The following is a description of a gene set: Abnormal increase or decrease of absolute number of granulocytes in the blood, per microliter, compared to a reference range for a given sex and age-group. Abnormal granulocyte count Human Gene Set: HP_ABNORMAL_GRANULOCYTE_COUNT studied in species Homo sapiens, and this is the list of marker genes: UNC93B1, TONSL, MTR, NLRP1, STXBP2, SPI1, CASP10, FANCE, RPS28, IL6ST, CXCR2, RNF113A, AP3B1, FAS, LAMTOR2, CDC40 (cell division cycle 40), MDM4, CSF3R, TSR2, DNAJC21, RPL35, STK4, ICOS, CD40, TLR8, PRF1, G6PC3, RPS26, SRP19, MECOM, PCCB, FIBP, CARD10, SLC35A1, PRKAR1A, STAT1, MMAB, PSMB10, ZBTB16, IFNG, JAGN1, ATRX, NABP1 (NCBI Gene Id 64859), GFI1, RPS24, TCIRG1, WAS (NCBI Gene Id 7454), TERT, TBX21, UBE2A, FCGR3B, KIT, TBL1XR1, RECQL4, RPL35A, AP3D1, RPS20, CARS1, CXCR4, PCCA, TINF2, ITCH, ETV6, ABCD4, DIAPH1, VPS33A, VPS45, MVK, MPLKIP, AK2, CD3D, IGLL1, MMACHC, RAC2, TLR3, LRRC8A, UNC13D, PACS2, NR3C1, TICAM1 (NCBI Gene Id 148022), RPL18, SMARCAL1, ZAP70, XIAP, FASLG, RBM8A, CARD9, JAK1, PIK3CG, FBXL4, CHD7, FDX2, NDUFA6, TRAC, FANCI, EPG5, MEFV, MTRR, GTF2E2, GTF2H5, BCL11B, RPL31, BCOR, TFR2, CDH23, USP8, PPIL1, EIF2AK3, STAT6, COG4, PRDX1, WIPF1, DOCK11, RAG1, SAMD9L, FBXW7, GINS1, BTK, TRAF3, TPP2, CRELD1 (cysteine rich with EGF like domains 1), ANAPC1, EFL1, LIG4, TAFAZZIN, BACH2, RPS7, RFX5, ARPC5 (NCBI Gene Id 10092), SRSF2, RPS29, FNIP1, BLNK, FIP1L1, PGM3, OTULIN, CEBPE, SRP54, PIK3CD, NLRP3, GATA2, RPL15, HLA-DRB1, TP53, RPS27, ICOSLG, STAT3, CBL, RPS17, FMO3, ERCC2, IL36RN, NUMA1, HEATR3, ASXL1, RAB27A, MAD2L2, IRF8, CDSN, EXTL3, RPL27, DOCK8, FOXP3, SLC37A4, LBR, STAT5B, FANCA, SF3B1, ERCC3, DCLRE1C, RNU4ATAC, RPL8, RPL5, IKBKG, FUT8, PTPN6, LRBA, CARD11, BTNL2, SLC39A7, CTLA4, CIITA, CD79A, RPS15A, SLC30A7, CD3E, SH2D1A, CAMK2B, SASH3, RPL26, NCAPG2, ZNF341 (NCBI Gene Id 84905), IPO8, FANCD2, MYSM1, SRP68, ACP5, PNP (NCBI Gene Id 4860), POLD3, CD247, CLPB, SLC27A4, ZNFX1, STX11, IRAK4, RPS19, RARA, RPS10, AARS1, SLC46A1, SAMD9 (NCBI Gene Id 54809), USB1, RELB, MMUT, CUBN, NPM1, LMBRD1, HAX1, HSCB, LYST, IL2RG (NCBI Gene Id 3561), GATA1, TCF3, TERC (NCBI Gene Id 7012, telomerase RNA component), PML, WDR1, MMAA, SMARCD2, SPINK5, CD79B, SBDS, MSN, CD40LG, SCO2, SLC35C1, AMN, GSS, USP48, RUNX1, KRAS, SEC61A1, FANCG, IL1RN, CAPN3, PDGFRA, GALE, TCN2, ELANE, IRF2BP2 (NCBI Gene Id 359948), TFRC, AGA, RPL11 (ribosomal protein L11), RFXANK, ADA2, ADA, BRAF, RAG2, RPL9, VPS13B, C1GALT1C1, NRAS, IGHM, PIK3R1, STAT4, RFXAP, FANCC, TET2, TARS1, TBK1, RMRP, SREBF1, TDP2, IL7R, HTRA2, THPO